The following is a description of a gene set: Human Gene Set: MIR6758_3P studied in species Homo sapiens from publication Chen Y, Wang X (PMID 31504780) Genes predicted to be targets of miRBase v22 microRNA hsa-miR-6758-3p in miRDB v6.0 with MirTarget v4 prediction scores > 80 (high confidence targets)., and this is the list of marker genes: RNF38, FOXC1 (forkhead box C1), USP49, PCLO, CTXN3, POT1, AAR2, OPN5, C11orf87, THEMIS2, DACH1, TMCO1, DIS3, TMEM167A, RPS3, RPL27A, ABHD2, FBXO21, ZNF124, KCNA6, APC, CNIH1, SGCB, MBNL3, LINGO2, KCND2, STRADA, ALG13, GABRR1, SNX15, EDAR, SNURF, ARHGAP6, ZNF676, CACUL1, METTL15, ZSCAN21 (zinc finger and SCAN domain containing 21), STON2, ZNF606, ZMYM2, MEGF10, CLDN19, FAM76A, MFSD6, NSDHL, DNAJC3, ATPSCKMT, SAR1B, C1QTNF2, C5orf47, SAV1, HIVEP3, KALRN, HTR2C, MAL2 (NCBI Gene Id 114569), TP53RK, KRT222, ZSWIM6, BAIAP2L1, SLC10A7 (NCBI Gene Id 84068), CX3CR1, TMX4, GABRB3, BRI3, NBN, ADD3, POSTN, NDUFB2, PRH2, PDSS2 (NCBI Gene Id 57107), YIPF6, PDZK1, SGMS2, WASHC4, NEU3, CAMSAP2, SEMA5A, CD164 (NCBI Gene Id 8763), NHLRC3, RNF170, RGS4, MKNK2, UPF2, MFSD4B, ACBD5, VDAC2, TRIM5, MSS51, NLK, TNIK, C12orf50, ROCK1, RALGPS2, FNIP1, APLN, TMEM161B, SORD, ASPH (aspartate beta-hydroxylase), KLF5, LRRC19, MAP7, DDI1, FAM184A, IGDCC3, FUT8, ERP44, AAK1, TLK1, SNTG1, GOLPH3L